Given this list of marker genes MICU1, PCDHGC3, SPRING1, PKP1, ATF7IP2, KCNJ12, TMEM94, DAGLA, NECTIN1, CLCC1, CPXM2, PNMA8B, KCNC1, TSKU, ZNF426, TNFSF8, CACNG2, KIF13A, PRAG1, EFR3B, TCF3, MXI1, TMEM217, PLEKHG4B, MISP, NDOR1, PRRT4, ALX4, GDF5, RHO, XPNPEP2, TRIM67, SLC24A2, NEURL1, MAVS, LRSAM1, ISY1, ADRA2B, MIGA2, ZNF471, SUFU, CEP250, ZNF609, ALAD, SLC7A8, YPEL4 (NCBI Gene Id 219539), MAP4, SRF, BZW1, RIMS4, RGS8, PTGES2, SYCP2L, ZFYVE27, SZT2, SLA, HNF1A, TRAF3, RABEP2, CXXC1, NCLN, SNPH, IP6K1, SPRED3, MDM4, MMP24, SNX33, TRARG1, SLC18A1, CHTF8, PAX7, WNT2B, PRR30, PABPC1, SYNC, MLEC, ORAI2, CA7, PRRC2A (proline rich coiled-coil 2A), SLC1A4, MRTFA, PDGFRB, ZNF483, TEF, SDK1, SORCS2, SPSB1, HHIPL2, PGPEP1, TCF12, MAU2, VPS37D, TPBGL, GIGYF2, TMEM184B, SYT7, ANKRD52, PREX2, ZBTB4, OR2H1, DEAF1, PFKFB3, EXOC4 (exocyst complex component 4), LSS, LARP1, TGIF2, KCNC2, TSPAN17, MIDEAS (mitotic deacetylase associated SANT domain protein), MTCL2, SPRYD3, KREMEN1, IFITM10, SET, CDIP1, GUF1, VASH1, RBFA, NHSL1, FAM53A, NPTX1, PPP2R5D, LZTS1, OCM, WSCD1, TMEM245, TMEM120B, GRK6, NEURL1B, KLK5, HEYL (hes related family bHLH transcription factor with YRPW motif like), C12orf75, TFE3, ZBTB2, STC1, NR2E1, C1RL, ARHGAP32, PCDHGA12, CALCR, PTPA, ANKRD34C, RNPEPL1, MGAT3, ARMC5, OLFML2A, ADCY6, RPH3A, ZNF474 (zinc finger protein 474), LIAT1, ICOSLG, MAFF, MAPKAPK2, CACFD1, PNLIPRP3, TMEM132B, GRM6, NAV1, LIN28A, MYRF, XRCC3, NDST1, SREBF2, TAGLN2 (transgelin 2), TMEM250, FBXL18, ZC3H12A, OVOL1, CD79A, RNF216, SUSD2, WNT3A, MEF2D, here is a description of the gene set: Human Gene Set: MIR1915_3P Genes predicted to be targets of miRBase v22 microRNA hsa-miR-1915-3p in miRDB v6.0 with MirTarget v4 prediction scores > 80 (high confidence targets). from publication Chen Y, Wang X (PMID 31504780) studied in species Homo sapiens